The following is a description of a gene set: Human Gene Set: MIR128_1_5P from publication Chen Y, Wang X (PMID 31504780) studied in species Homo sapiens Genes predicted to be targets of miRBase v22 microRNA hsa-miR-128-1-5p in miRDB v6.0 with MirTarget v4 prediction scores > 80 (high confidence targets)., and this is the list of marker genes: NRM, TBC1D25 (TBC1 domain family member 25), SUGP2 (NCBI Gene Id 10147), CDH15, CBFA2T3, IQSEC2, SDK1, GNG13, RHOA, EFNB3, DUSP8, TMED7-TICAM2, TMEM86B, IQSEC3